Given this list of marker genes Pkp2 (plakophilin 2), Eppk1, Nefl (neurofilament, light polypeptide), Nefm, Nefh, Krt14, Pkp1, Bbln, here is a description of the gene set: species: Mus musculus Mouse Gene Set: GOBP_INTERMEDIATE_FILAMENT_BUNDLE_ASSEMBLY The formation of the bundles of intermediate filaments. Intermediate filament-associated proteins (IFAPs) cross-link intermediate filaments with one another, forming a bundle or a network, and with other cell structures, including the plasma membrane. The organization of intermediate filaments and their supportive function in various cells types depends in large part on their linkage to other cell structures via IFAPs.